Given this list of marker genes IRS2, THBS1, AKT1, AKT2, ACSL1, ACSL5, here is a description of the gene set: species: Homo sapiens Human Gene Set: GOBP_REGULATION_OF_LONG_CHAIN_FATTY_ACID_IMPORT_ACROSS_PLASMA_MEMBRANE Any process that modulates the rate, frequency or extent of plasma membrane long-chain fatty acid transport. Plasma membrane long-chain fatty acid transport is the directed movement of long-chain fatty acids across the plasma membrane. A long-chain fatty acid has an aliphatic tail containing 13 to 22 carbons.